Given this list of marker genes STK39, MAGED2, EDNRB, KLHL3, UMOD, KCNQ1, GUCA2B, OXSR1, SLC12A3, SGK1, CLCNKB, KCNJ1, EDN1, WNK3, WNK4, EDNRA, here is a description of the gene set: species: Homo sapiens A renal system process in which sodium ions are taken up from the collecting ducts and proximal and distal loops of the nephron. In non-mammalian species, absorption may occur in related structures. Human Gene Set: GOBP_RENAL_SODIUM_ION_ABSORPTION